The following is a description of a gene set: Mouse Gene Set: GOBP_VITAMIN_B6_METABOLIC_PROCESS species: Mus musculus The chemical reactions and pathways involving any of the vitamin B6 compounds: pyridoxal, pyridoxamine and pyridoxine and the active form, pyridoxal phosphate., and this is the list of marker genes: Pdxk, Plpbp, Pdxp, Alpl, Pnpo (NCBI Gene Id 103711)